The following is a description of a gene set: studied in species Mus musculus part of: GPCR downstream signalling This event has been computationally inferred from an event that has been demonstrated in another species.<p>The inference is based on the homology mapping from PANTHER. Briefly, reactions for which all involved PhysicalEntities (in input, output and catalyst) have a mapped orthologue/paralogue (for complexes at least 75% of components must have a mapping) are inferred to the other species. electronically inferred by orthology from the curated human pathway Reactome Pathway: G alpha (q) signalling events, and this is the list of marker genes: Prokr1, Mchr1, P2ry2, Npff, Nmur1, Rgs1, Opn4 (opsin 4 (melanopsin)), Gng7, Trhr, Casr (NCBI Gene Id 12374), Gng4, Gcg, Gnrhr, Hcrt, Lpar3, Daglb, Ccl6, Plcb3, Dgkh, Xcr1, Grpr, Kiss1r, Ghsr, Chrm3, Ltb4r1, Prokr2, Tacr1, Gpr132, Dgka, Nmu, Ffar3, Bdkrb1, Nmb, Rgs4, Avpr1b, Chrm1, Qrfp, Grb2, Rgs13, Lpar2, Brs3, Trpc7, Gnb5, Trpc6, Tbxa2r, Trh, Nms, Rgs18, Lpar5, Ntsr2, Egfr, Gngt1, Cckar (cholecystokinin A receptor), Gcgr, Gng8, Dgkb, Gng10, Gngt2, Qrfprl, Gng5, Npsr1, Gnb2, Rgs2, Hcrtr1, Ccl9, Gng11, Mmp3, Ptger1, Tac2, Cck, Avpr1a, Gpr65, Hcrtr2, Lpar6, Ffar1, Edn3, Oxt, Ffar2 (NCBI Gene Id 233079), F2, Gpr68, Npffr1, Gprc6a, Kng2, Mapk3, Ntsr1, Uts2r, Avp, P2ry1, Prok2, Htr2c, Gna14, Hrh1, Oxtr, Mapk7 (NCBI Gene Id 23939), Dgki, Nts, Kiss1, F2rl3, Cckbr, Uts2b, Tacr2, Edn1, F2rl1, Rgs16, Hras, Prkca, P2ry10, Cysltr2, Gpr143, Gpr17, Gpr4, Gng3, Prok1, Gast, Grp, Nmur2, Gnb3, Bdkrb2, Cysltr1, Prkch, Lpar4 (lysophosphatidic acid receptor 4), Ednrb, Adra1a, Uts2, Edn2, Dagla, Pik3r2